The following is a description of a gene set: Hydrolysis of a ubiquitin unit from a ubiquitinated protein linked via the Lys63 residue of ubiquitin. Mouse Gene Set: GOMF_K63_LINKED_DEUBIQUITINASE_ACTIVITY studied in species Mus musculus, and this is the list of marker genes: Brcc3, Otud5, Usp14, Tnfaip3, Otud4, Usp8, Stambp, Cyld, Usp27x, Usp9x, Usp53, Atxn3, Brcc3dc, Stambpl1, Desi2 (NCBI Gene Id 78825)